The following is a description of a gene set: A simultaneous engagement of different pathogen recognition receptors provides a tailor made adaptive immunity for an efficient defence against distinct pathogens. For example, cross talk of TLR and c-type lectin signalling effectively shapes distinct gene expression patterns by integrating the signals at the level of NF-κB. Here, we extend this principle to a strong synergism between the Dectin-1 agonist, curdlan, and an inflammatory growth factor, GM-CSF. Both together act in synergy in inducing a strong inflammatory signature which converts immature DCs to potent effector DCs. A variety of cytokines (IL-1β, IL-6, TNF-α, IL-2 and IL-12p70), costimulatory molecules (CD80, CD86, CD40 and CD70), chemokines (CxCl1, CxCl2, CxCl3, CCl12, CCl17) as well as receptors and molecules involved in fugal recognition and immunity such as Mincle, Dectin-1, Dectin-2 and Pentraxin 3 are strongly up-regulated in DC treated simultaneously with curdlan and GM-CSF. The synergistic effect of both stimuli resulted in strong IKBα phosphorylation, in its rapid degradation and in enhanced nuclear translocation of all NF-κB subunits. We further identified MAPK ERK, as one possible integration site of both signals, since its phosphorylation was clearly augmented when curdlan was co-applied with GM-CSF. Our data demonstrate that the immunomodulatory activity of curdlan requires an additional signal provided by GM-CSF to successfully initiate a robust β-glucan specific cytokine and chemokine response. The integration of both signals clearly prime and tailor a more effective innate and adaptive response against invading microbes and fungi. from publication Min L, Isa SA, Fam WN, Sze SK, Beretta O, Mortellaro A, Ruedl C (PMID 22250091) studied in species Homo sapiens Human Gene Set: GSE32986_GMCSF_VS_GMCSF_AND_CURDLAN_HIGHDOSE_STIM_DC_DN Genes down-regulated in bone marrow-derived dendritic cells CSF2 versus CSF2 and high dose of 1,3-beta-D-oligoglucan., and this is the list of marker genes: GGA2, C19orf18, MICAL3, MORF4, SLC30A1, WEE1, TRIM2, ING5, LINC00910, CEP68, RUBCN, PFN2, VAC14, RTN4IP1, MIR26A2 (NCBI Gene Id 407016), MAPK1 (mitogen-activated protein kinase 1), GEN1 (GEN1 Holliday junction 5' flap endonuclease), RTTN, DMXL1, DNAI7, ALDH18A1, TEX2, FHL2, SNORA30, CDK4, MAGEE1, NSD3, GPR137B, ZNF676, IQCN, SLC26A11, RALGAPA2, JADE2, C1orf162, SAA2, MRTFB (myocardin related transcription factor B), OGG1, TAF1C, CCDC88A, LIMK2, ERICH3, AADACL2, STBD1, PDLIM5, OR9I1, HIRA, CLCN6, FZD6, YJU2, FCER1A, THOC1, BMPR2, NBPF7P, SNORD115-8, ACCSL, DIDO1, AHI1, NUDT13, KMT2C, SERPINB9, NUDT9P1, PER2, ST6GAL1, CLGN, TEX261, CDON, MPHOSPH9, CCAR1, IGSF9B, ZNF788P, MADD, GPR21, SEPTIN8, ENPP1, SPINT4, ZFYVE26, CHD8, SLC39A14 (NCBI Gene Id 23516), ALOX12P2, ATXN1, TMA7, EPB41L3, TERF1P2, NFATC3, UGP2, AFG2B, USP11, ARHGAP29, TMTC2, PLK2, NAP1L5, CAPN11, SMURF2, BRI3, PIK3CD, DENND1B, OR52H1, NFIL3 (NCBI Gene Id 4783), RBBP4, SFMBT1, PECAM1, HPS4, NPC2, HPSE, WDTC1, B3GNT2, CHKA, GPRASP1, SNED1, ACACB, PPP1R12B, KIF1B, ACVR2A, DNAH1, MIR423, VPS18, FMN1, SERPINB6, SLC47A1, CD84, ASXL2 (NCBI Gene Id 55252), PTGER4, NAPA, INPP5F, MAFG, ANAPC7, GLMP, HECTD4, VWA8, SLC36A1 (solute carrier family 36 member 1), ZEB1, CNR2, MLLT10, TAS2R5, MED15, CLIC6, APBB1, SLC12A6, ITSN1, LIMD1 (LIM domain containing 1), SMG1, STEAP1, SNRPN (small nuclear ribonucleoprotein polypeptide N), ZNF280C, CAPZA3, SYNE2, ITPKB, EVI5, SGTA, SINHCAF, MBOAT2, HOMER2, ZSCAN9, TGFBR3, SMG5, RASGRP3, DDX28, NAP1L3, SERPINB10, NFKB1, KPNA6, CNNM3, OR5D18, ZHX2, ENPP3, CNOT1, OXGR1, STAU1, CYB5RL, TPP1, NCOA3, MAN1C1, GLRX2, FAM185A, NEDD9, MAN2A1, IMPACT, ALDH5A1, F11, TSC22D1, ZNF318, DOCK10, IL6ST (NCBI Gene Id 3572), AXIN2, TLR5, PIK3CG, MCOLN3, MYOM1, ZNF738, DNAI3, ARMCX6, KANSL1L, DGKH, CYSLTR2, OR5AK3P, ZNF682 (NCBI Gene Id 91120), MIR125B1, ZNF799